The following is a description of a gene set: electronically inferred by orthology from the curated human pathway Reactome Pathway: RND2 GTPase cycle part of: RHO GTPase cycle species: Mus musculus This event has been computationally inferred from an event that has been demonstrated in another species.<p>The inference is based on the homology mapping from PANTHER. Briefly, reactions for which all involved PhysicalEntities (in input, output and catalyst) have a mapped orthologue/paralogue (for complexes at least 75% of components must have a mapping) are inferred to the other species., and this is the list of marker genes: Epha2, Txnl1, Kidins220, Frs2, Plxnd1 (NCBI Gene Id 67784), Vangl2, Depdc1b, Vangl1, Ubxn11, Lrrc1, Pik3r2, Wdr6, Rnd2, Ckap4, Muc13, Rbmx, Tnfaip1, Nudc, Cav1, Ptpn13, Dsg1a, Fam83b, Ktn1